Given this list of marker genes Pank2 (pantothenate kinase 2), Ppcs, Ppcdc, Pank1, Pank3, Coasy, Dcakd, here is a description of the gene set: species: Mus musculus Mouse Gene Set: REACTOME_COENZYME_A_BIOSYNTHESIS Coenzyme A biosynthesis